Given this list of marker genes Adamts3, Jcad, Tspan32, Dab2ip, Xdh, Emilin1, Tcf4, Adamts12, Itgb3, Pik3cb, Itgb1, Smoc2, Robo1, Adgrg1, Adgra2, Dll1, Dcn (decorin), Cd63, Vtn, Vegfa, Ccbe1, Cadm4, Il12a, Spry2, Il12b, Hrg, Itga5, Ptp4a3, Atp2b4, Sema6a, here is a description of the gene set: Mouse Gene Set: GOBP_REGULATION_OF_CELLULAR_RESPONSE_TO_VASCULAR_ENDOTHELIAL_GROWTH_FACTOR_STIMULUS species: Mus musculus Any process that modulates the frequency, rate or extent of cellular response to vascular endothelial growth factor stimulus.